Given this list of marker genes CYBB, ATP6V0C, STING1, ATP5MG, ATP5MGL, OTOP1, MT-ATP8, HVCN1, ATP5F1D, ATP5F1C, ATP5PB, ATP5PF, ATP5F1EP2, TMEM175, ASIC5, MT-ATP6 (mitochondrially encoded ATP synthase membrane subunit 6), NOX5, ATP5F1E, ATP5ME, ATP5PD, ATP5MF, ATP5MC1, ATP5PO, OTOP3, SLC4A11, OTOP2, ATP5F1A, ATP5F1B, here is a description of the gene set: Human Gene Set: GOMF_PROTON_CHANNEL_ACTIVITY studied in species Homo sapiens Enables the facilitated diffusion of a hydrogen ion (by an energy-independent process) involving passage through a transmembrane aqueous pore or channel without evidence for a carrier-mediated mechanism.